Given this list of marker genes MTM1, PKD1, MAPT, ARMC1, MYO19, MSTO1, TRAK2, TRAK1 (trafficking kinesin protein 1), TSPAN9, KAT2A, OPA1, BHLHA15, CLUH, SLC4A5, ATCAY, DNM1L, MEF2A, EPCIP, KIF5B, LRRK2, HAP1, here is a description of the gene set: studied in species Homo sapiens Any process that establishes the spatial arrangement of mitochondria between and within cells. Human Gene Set: GOBP_MITOCHONDRION_DISTRIBUTION